The following is a description of a gene set: species: Homo sapiens Reactome Pathway: MyD88 dependent cascade initiated on endosome part of: Toll Like Receptor 7/8 (TLR7/8) Cascade; Toll Like Receptor 9 (TLR9) Cascade Upon binding of their ligands, TLR7/8 and TLR9 recruit a cytoplasmic adaptor MyD88 and IRAKs, downstream of which the signaling pathways are divided to induce either inflammatory cytokines or type I IFNs., and this is the list of marker genes: PELI3, IRAK1, FBXW11, CASP8, AGER, TICAM1, PPP2CA, MAP3K8, TP53, NFKBIB, MAPK8, MAP3K1, USP18, MAPKAPK3, RPS6KA3, UBE2V1, PPP2R1B, MAP3K7, IKBKG, MEF2C, UBE2N, ATF2, N4BP1, HMGB1, IRF7, RIPK2, TIFA (TRAF interacting protein with forkhead associated domain), TLR9, RPS6KA5, MAPK14 (mitogen-activated protein kinase 14), S100A12, ALPK1, RPS27A, MAPK7, UBA52, IKBIP, NFKBIA, DUSP6, NFKB2, MAP2K1, LRRC14, S100B, IKBKB, CUL1, MAPKAPK2, DUSP7, MAP2K6, N, TAB2, CD14, DUSP3, PELI2, NOD1, PELI1, RPS6KA2, NOD2, TRAF6, NLRC5, IRAK4 (NCBI Gene Id 95458), TLR4, TAB3, LY96, TRAF2, MAPK10, TICAM2, TNIP2, VRK3, MAPK1, NLRX1, PPP2CB (protein phosphatase 2 catalytic subunit beta), USP14, CREB1, SAA1, MAP2K7, MYD88, TLR7, MAPK9, MAP2K4, SKP1, NKIRAS2, MAPK3, ATF1, RELA, APP, PPP2R1A, IRAK2, CHUK, ECSIT, JUN, TAB1, MAP2K3, RPS6KA1, UBC, DUSP4, FOS, NKIRAS1, NFKB1, MAPK11, PPP2R5D, ELK1, MEF2A, BTRC, UBB